The following is a description of a gene set: studied in species Mus musculus Binding to an immunoglobulin of the IgM isotype. Mouse Gene Set: GOMF_IGM_BINDING, and this is the list of marker genes: Pira13, Fcmr, Pira12, Pira2, Lilra6, Cd300lg, Fcamr